Given this list of marker genes RAD51B, SERTAD2, RANBP9, MTPN, DUSP13A, here is a description of the gene set: Genes predicted to be targets of miRBase v22 microRNA hsa-miR-105-3p in miRDB v6.0 with MirTarget v4 prediction scores > 80 (high confidence targets). from publication Chen Y, Wang X (PMID 31504780) species: Homo sapiens Human Gene Set: MIR105_3P